The following is a description of a gene set: Mouse Gene Set: GOBP_FIBROBLAST_PROLIFERATION The multiplication or reproduction of fibroblast cells, resulting in the expansion of the fibroblast population. studied in species Mus musculus, and this is the list of marker genes: Meox2, Ifng, Rasa1, Gpx1, Brpf1, Esr1, Gas6, Prdx1, Gng2, Zmpste24, Wnt2, Ager, Men1, Xrcc4, Jun, Pawr, Nras, Dph1, Pdgfrb, Zmiz1, Ctc1, Inca1, Kcnj8, Igf1, Pdgfb, Ski, Wnt1, Pmaip1, Lta, Myc, Parp10, Btc, Dazap1, Kmt2a, Pdgfra, Col3a1, Agt, Fam114a1, Fntb, Brk1, Ereg, Nlrc3, Fn1, Cav1, Rpl29, Creb1, Sod2, Morc3, Tgif1, Ccna2, Cks1b, Serpine1, Sp2, Pla2g1b, E2f8, Trim32, C1ql4, Egfr, Trp53inp1, Sirt6, Mif, Fgf10, Agtr2, Nf1, Nupr1, Smarca2, Fbrs, Kcnn4, Uts2, Fbxo4, Pml, Cdk6, BC004004, Itgb3, Anxa2 (annexin A2), Aqp1, Fbln1, Pdgfd, Kdm8, Cd248, Rrn3, Sphk1, Ifi30, Vegfd, Wnt5a, Trp53, Bmyc, Lig4, Mir744, Nbn, Tgfb1, Lif, Ngfr, Tsc2 (NCBI Gene Id 22084), Emd, Fndc3b, Cripto, Rnaseh2b, Sfrp1, Hmga2, Zfp469, Phip, Cdc6, Ednra (endothelin receptor type A), Med25, Ptprv, Ptprz1, Grk2, Myb, Ecd, Abl1, Pex2, Socs1 (NCBI Gene Id 12703), B4galt7, Cdkn1a, Cdc73, Pes1, Pparg, Cks2, Pdgfa, Pdgfc, Icmt, Dach1, Ccnb1, Morf4l1, Mmp9, Gstp1, Bax, Kmt2c, E2f1, Med31, Fth1, Cdk1, Cd300a, Rasgrf1 (NCBI Gene Id 26449), Egf, Hras (Harvey rat sarcoma virus oncogene), Fosl2, Kat2a, Prkdc (NCBI Gene Id 19090), Ing5, Bmi1, Uts2r, Ptges3, Il13, Dicer1, Dab2ip, Lzts2, Cdk4, Dhx9, Ndufs4, Ddr2, Cd74, Abcc9